The following is a description of a gene set: Human Gene Set: GOBP_THIAMINE_DIPHOSPHATE_BIOSYNTHETIC_PROCESS species: Homo sapiens The chemical reactions and pathways resulting in the formation of thiamine diphosphate, a derivative of thiamine (vitamin B1) which acts as a coenzyme in a range of processes including the Krebs cycle., and this is the list of marker genes: TPK1 (NCBI Gene Id 27010), SLC19A3, SLC25A19, THTPA, SLC19A2